The following is a description of a gene set: from publication Foroutan M, Cursons J, Hediyeh-Zadeh S, Thompson EW, Davis MJ (PMID 28119430) Most cancer deaths are due to metastasis, and epithelial-to-mesenchymal transition (EMT) plays a central role in driving cancer cell metastasis. EMT is induced by different stimuli, leading to different signaling patterns and therapeutic responses. TGF_ is one of the best-studied drivers of EMT, and many drugs are available to target this signaling pathway. A comprehensive bioinformatics approach was employed to derive a signature for TGF_-induced EMT which can be used to score TGF_-driven EMT in cells and clinical specimens. Multiple datasets were used to derive the signature using three approaches: by integrating the datasets prior to identifying EMT genes, by first identifying EMT genes from individual datasets and then combining them using a meta-analysis (product of ranks) approach, and by combining inferences from the first two approaches. Genes up-regulated in the epithelial-mesenchymal transition (EMT) upon transforming growth factor beta (TGFb) stimulation derived from multiple datasets using a product of ranks meta-analysis approach. Human Gene Set: FOROUTAN_PRODRANK_TGFB_EMT_UP studied in species Homo sapiens, and this is the list of marker genes: TPM1 (tropomyosin 1), TUBA4A, LAMC2, CYTH1, MMP2, ANGPTL4, DSE, ACKR3, CALD1, ACTN1, IL11, CDH2, FERMT2, GREM1, GFPT2, PSMD2, JARID2, SCG5, PTPN21 (NCBI Gene Id 11099), DUSP10, PDGFA, ZNF365, CHRNA9, WNT5A, RUNX2, PLAUR, PTHLH, SRPX, WNT5B, RGS4, MAGED2, BPGM, ANKLE2, TP53I3, SNAI2, LBH, KCNMA1, GAL, APBB2, BMP1, BMP2, ITGA5, COL5A1, NCF2, SERPINE1, MMP9, COL4A1, ALOX5AP, PALLD, NKX3-1 (NK3 homeobox 1), KDELR3, MATN3, NRIP3, IGFBP5, SLC26A2, LOX, XYLT1, INHBA, SIK1, C3orf52, SACS, SPHK1, TPM4, TMCC1, PLEK2, SMURF2, LARP6, RALA, MN1 (MN1 proto-oncogene, transcriptional regulator), SPOCK1, ITGB3, TGFB1, SLC22A4, NEDD9, GADD45B, DLC1, SEMA3C, FAM114A1, PDGFC, SPARC, BMAL1, MMP10, PIK3CD (phosphatidylinositol-4,5-bisphosphate 3-kinase catalytic subunit delta), PID1, MYL9, HMOX1, FN1, COL4A2, FOXD1, IGFBP7, SLN, SKIL, TIMP2, PRR5L, LMCD1 (LIM and cysteine rich domains 1), ETS2, EPHB2, THBS1, DACT1, NUAK1, CHST11, MRC2, TAGLN2, STC1 (stanniocalcin 1), SMAD7, SLCO2A1, TNS1, ADAMTS6, MYO10, SPDL1, VEGFC, PMEPA1, TAGLN, PTPRK, GNG11, TBX3, TCF4, JAG1, HS3ST3A1, DOCK4, ADAM12, TUFT1, KLF7, NT5E, CRLF1, MFAP2, TGFB1I1, JUN, FHOD3, VCAN, INPP4B, SRRD, TUBA1A, MMP1, POSTN, CDK14, HTRA1, DAAM1, DHRS2, TGFBI, ARHGEF40, COL1A1, PDLIM7, ABCA1, PXDC1 (PX domain containing 1), TPST2, HMGA2, HRH1, CDH11, AKT3, SERPINE2 (serpin family E member 2), PEA15, MBOAT2, TPST1, RFTN1, AP1S2, DIXDC1, PODXL, KCNJ15, COL7A1, MAP1LC3B, FSTL3, ELK3, GALNT10, GASK1B, EML1, AMIGO2, JUNB, VIM, ADAM19, ARFGAP1, CD59, CCN2, GLIPR1, TFPI2, HSF2BP, BHLHE40, NREP, TGM2, MICAL2, FBN1, BMPR2, TNFAIP6, GRB10, MAF